The following is a description of a gene set: electronically inferred by orthology from the curated human pathway studied in species Mus musculus Reactome Pathway: Activation of G protein gated Potassium channels This event has been computationally inferred from an event that has been demonstrated in another species.<p>The inference is based on the homology mapping from PANTHER. Briefly, reactions for which all involved PhysicalEntities (in input, output and catalyst) have a mapped orthologue/paralogue (for complexes at least 75% of components must have a mapping) are inferred to the other species. part of: G protein gated Potassium channels, and this is the list of marker genes: Kcnj3, Gabbr1, Gng7, Gng3, Kcnj10, Gng5, Gnb3, Gng11, Kcnj12 (NCBI Gene Id 16515), Gnb2, Gng8, Gngt1, Gng4, Kcnj2, Gng10, Kcnj5, Gnb5, Gngt2